Given this list of marker genes WNT16, PAX2, PHACTR4, SOX11, WNT5A, TFAP2A, ALDH1A3, here is a description of the gene set: Human Gene Set: GOBP_OPTIC_CUP_MORPHOGENESIS_INVOLVED_IN_CAMERA_TYPE_EYE_DEVELOPMENT studied in species Homo sapiens The invagination of the optic vesicle to form two-walled indentations, the optic cups, that will go on to form the retina. This process begins with the optic vesicle becoming a two-walled structure and its subsequent shape changes. It does not include the fate commitment of cells to become the pigmented retina and the neural retina. An example of this process is found in Mus musculus.